Given this list of marker genes GUCY2D, CLEC3B, PRPH2, SLC24A5, OPN1LW, PAX6, TRIM44, RLBP1, GUCA1A, OPN1MW, FOXC1, here is a description of the gene set: Abnormal foveal morphology on macular OCT Human Gene Set: HP_ABNORMAL_FOVEAL_MORPHOLOGY_ON_MACULAR_OCT studied in species Homo sapiens